The following is a description of a gene set: Human Gene Set: GOBP_ACTIN_FILAMENT_POLYMERIZATION studied in species Homo sapiens Assembly of actin filaments by the addition of actin monomers to a filament., and this is the list of marker genes: TMOD3, MIR214, TMOD1, PFN3, SVIL, SPTBN1, PAK3, CAPZA3, VILL, SPTBN2, NCK1, PYCARD, LMOD3, CCR7, RDX, INF2, LATS1, CYRIB, WASHC3, DLG1, KANK1, DIAPH3, WASF3, BAG4, ARHGAP40, CCL21, ARFGEF1 (ADP ribosylation factor guanine nucleotide exchange factor 1), CORO7, FER, CDC42EP1, NCK2 (NCK adaptor protein 2), SLIT2, JAK2, WASL, CDC42EP3, DIAPH1, RICTOR, CARMIL1, ARPC4 (actin related protein 2/3 complex subunit 4), ARPC5L, SSH3, ARPC2, CRACD, PFN1, CD2AP, ARPC3 (NCBI Gene Id 10094), BAIAP2, CFL1, SSH1, CSF3, TWF2, ARF6, CDC42EP5, KANK4, MSRB1, TMOD2, CCL11, CTTN, TTC17, CAPG, SPTBN4, TENM1, BAIAP2L1, KIRREL1, COBL, FHDC1, ANG, WASHC2C, CCL24, CYFIP1, FAM107A, GBA2, VASP, AVIL, TRIOBP, BBS4, AIF1, PFN2, SPTB, ADD1, ADD3, GSN, KANK2, MYADM, TMOD4 (NCBI Gene Id 29765), ADD2, MSRB2, HIP1R, SPTA1, CAPZA2, RAC1, CAPZA1, HCLS1, ARHGAP28, KANK3, DIAPH2, MKKS, MLST8, C15orf62, MTOR, BAIAP2L2, PRKCE (NCBI Gene Id 5581), DAAM2, CARMIL2, TWF1, CORO1A, GRB2, LMOD2, NPHS1 (NPHS1 adhesion molecule, nephrin), ALOX15, SPTBN5, FCHSD2, DMTN, CAPZB, CDC42EP2, FLII, HCK, EPS8, CYRIA, RHOD, ASB2, ARHGAP6, MICALL2, PREX1, TMSB4X, ABITRAM, MTPN, NCKAP1L, LMOD1, WAS, COTL1, NCKAP1, VIL1, CATIP, WASHC5, ELN, SCIN, RASA1, CCL26, ARHGAP18, PLEKHG2, SNX9, ARPC5 (NCBI Gene Id 10092), PRKCD, BIN1, CDC42EP4, CYFIP2, PIK3R2, ESAM, WASF1, SPTAN1, EVL, PTK2B, ABL1, HAX1, FCHSD1, SSH2